The following is a description of a gene set: studied in species Homo sapiens The initial, indirect interaction between a vesicle membrane and a membrane to which it is targeted for fusion. This interaction is mediated by tethering factors (or complexes), which interact with both membranes. Interaction can occur via direct binding to membrane phospholipids or membrane proteins, or via binding to vesicle coat proteins. This process is distinct from and prior to interaction between factors involved in fusion. Human Gene Set: GOBP_VESICLE_TETHERING, and this is the list of marker genes: TRAPPC2, EXOC2, EXOC7, TBC1D23, TRIP11, STARD3NL, STARD3, EXOC3, C17orf75, TRAPPC3, EXOC8, TRAPPC9, EXOC4, TRAPPC5, TRAPPC2B, TRAPPC6A, TRAPPC2L, NAGLU, WDR11, EXOC5, FAM91A1, TRAPPC6B, TRAPPC10, TRAPPC8, EXOC6, TRAPPC11, TRAPPC13, TRAPPC12, EXOC1 (exocyst complex component 1), TRAPPC4, TRAPPC1, EXOC6B